The following is a description of a gene set: Human Gene Set: NEWMAN_ERCC6_TARGETS_UP Cockayne syndrome (CS) is an inherited neurodevelopmental disorder with progeroid features. Although the genes responsible for CS have been implicated in a variety of DNA repair- and transcription-related pathways, the nature of the molecular defect in CS remains mysterious. Using expression microarrays and a unique method for comparative expression analysis called L2L, we sought to define this defect in cells lacking a functional CS group B (CSB) protein, the SWI/SNF-like ATPase responsible for most cases of CS. Remarkably, many of the genes regulated by CSB are also affected by inhibitors of histone deacetylase and DNA methylation, as well as by defects in poly(ADP-ribose)-polymerase function and RNA polymerase II elongation. Moreover, consistent with these microarray expression data, CSB-null cells are sensitive to inhibitors of histone deacetylase or poly(ADP-ribose)-polymerase. Our data indicate a general role for CSB protein in maintenance and remodeling of chromatin structure and suggest that CS is a disease of transcriptional deregulation caused by misexpression of growth-suppressive, inflammatory, and proapoptotic pathways. species: Homo sapiens Genes up-regulated in Cockayne syndrome fibroblasts rescued by expression of ERCC6 off a plasmid vector. from publication Newman JC, Bailey AD, Weiner AM (PMID 16772382), and this is the list of marker genes: SRI, HERC5, DBF4, PCSK5, STEAP1, CRIP1 (cysteine rich protein 1), FABP5, RGCC, CRACD, LITAF, SLC25A40, PMAIP1, CSTA, CXCL8 (C-X-C motif chemokine ligand 8), ALX1, CLDN23, MYLIP, ABCB1, SLC7A11, SLC38A1, KYNU, CXCL2, TNFAIP6, IFIT2, GPAT3, CD24P2